The following is a description of a gene set: Metastatic disease is the primary cause of death in cutaneous malignant melanoma (CMM) patients. To understand the mechanisms of CMM metastasis and identify potential predictive markers, we analyzed gene-expression profiles of 34 vertical growth phase melanoma cases using cDNA microarrays. All patients had a minimum follow-up of 36 months. Twenty-one cases developed nodal metastatic disease and 13 did not. Comparison of gene expression profiling of metastatic and nonmetastatic melanoma cases identified genes with a >2-fold differential expression ratio and a false discovery rate of <0.2 (206 up-regulated and 37 down-regulated). This set of genes included molecules involved in cell cycle and apoptosis regulation, epithelial-mesenchymal transition (EMT), signal transduction, nucleic acid binding and transcription, protein synthesis and degradation, metabolism, and a specific group of melanoma- and neural-related proteins. Validation of these expression data in an independent series of melanomas using tissue microarrays confirmed that the expression of a set of proteins included in the EMT group (N-cadherin, osteopontin, and SPARC/osteonectin) were significantly associated with metastasis development. Our results suggest that EMT-related genes contribute to the promotion of the metastatic phenotype in primary CMM by supporting specific adhesive, invasive, and migratory properties. These data give a better understanding of the biology of this aggressive tumor and may provide new prognostic and patient stratification markers in addition to potential therapeutic targets. Human Gene Set: ALONSO_METASTASIS_EMT_DN from publication Alonso SR, Tracey L, Ortiz P, Pérez-Gómez B, Palacios J, Pollán M, Linares J, Serrano S, Sáez-Castillo AI, Sánchez L, Pajares R, Sánchez-Aguilera A, Artiga MJ, Piris MA, Rodríguez-Peralto JL (PMID 17409456) EMT (epithelial-mesenchymal transition) genes down-regulated genes in melanoma tumous that developed metastatic disease compared to primary melanoma that did not. species: Homo sapiens, and this is the list of marker genes: EDN2, PAPPA, PCDH9, WNT2, CDH10